Given this list of marker genes Atg101, Ulk1, Rb1cc1, Tbc1d5, Smcr8, Sesn2, C9orf72, Wdr41, Atg13 (autophagy related 13), here is a description of the gene set: studied in species Mus musculus A protein complex consisting of Atg1 (or Atg1 homologs e.g. ULK1, ULK2 in mammals) and Atg13 along with other proteins that regulate its function (e.g. Atg17 in yeast or RB1CC1(FIP200) in mammals). This complex has serine/threonine protein kinase activity and is involved in autophagosome formation. Mouse Gene Set: GOCC_ATG1_ULK1_KINASE_COMPLEX